Given this list of marker genes MYH7, CAV1, MYL2, MYH6, APLN, GRK2, CHGA, GLRX3, NOS3, MYL4, ATP1A2, GAA, EDN2, CSRP3, NOS1, CAMK2D, ADRA1A, ATP1A1, ATP2B4, RYR2 (ryanodine receptor 2), SLC9A1, PLN (NCBI Gene Id 5350), MYL3, ADRB1, SLC8A1, ATP2A2, here is a description of the gene set: Human Gene Set: GOBP_REGULATION_OF_THE_FORCE_OF_HEART_CONTRACTION studied in species Homo sapiens Any process that modulates the extent of heart contraction, changing the force with which blood is propelled.